Given this list of marker genes DPYS, DPYD, UPP1, NT5C, UPB1, UPP2, here is a description of the gene set: studied in species Homo sapiens The chemical reactions and pathways involving dCMP, deoxycytidine monophosphate. Human Gene Set: GOBP_DCMP_METABOLIC_PROCESS